The following is a description of a gene set: Mouse Gene Set: GOMF_OXIDOREDUCTASE_ACTIVITY_ACTING_ON_DIPHENOLS_AND_RELATED_SUBSTANCES_AS_DONORS Catalysis of an oxidation-reduction (redox) reaction in which a diphenol or related substance acts as a hydrogen or electron donor and reduces a hydrogen or electron acceptor. species: Mus musculus, and this is the list of marker genes: mt-Cytb, Uqcrh, Cyc1 (cytochrome c-1), Nqo2 (NCBI Gene Id 18105), Cyp1a1, Uqcrfs1, Uqcrh-ps1, Lacc1